Given this list of marker genes H2BC26, MTA1, PCK1, ARID1B, MBD3L2, TCF19, CREBBP, SF3B1, CHD8, CDK2AP1, SNRPB2, SUMO1, SMARCD3, BCL11B, NS, BCL7C, H2BC4, H4C1 (H4 clustered histone 1), H2AB1, RTF1, MBD3L1, IKZF3, SF3B4, NFE2L2, EP300 (E1A binding protein p300), CDK2AP2, BICRA, H2BC15, SNRPD2, SMARCA2, DPF2, H2BC14, SKIC8, CTCF, H2AC20, H2BC13, H2AC18, DPF3, PHF10, SS18, H2BC12, SS18L1, HDAC1, BICRAL, ADNP, PBRM1, NQO1, PAF1, ACTL6B, CTNNB1, CHERP, CDC73, SUPT16H, DDX46, ADNP2, SF3A3, NP, U2SURP, SF3B3, MBD3, TCF12, ACTL6A, RBBP4, PA, ARID2, PUF60, TCF4, CBX1, H2AC6, HDAC2, IKZF1, PHF5A, PB2, MTA3, NR2F2, CHD4, H2BC17, H2BC12L, H3-3A, H2AJ, PWWP2B, CTR9, ZNF687, SNRPG, CBX3, GATAD2B, H2AC14, NR2C2, SSRP1 (structure specific recognition protein 1), SF3B2, PHF6, H2BC1, DHX15, FAM124B, CHD1, H2AC4 (H2A clustered histone 4), CHD3, ARID1A, DPF1, H2AC7, ZMYND8, SMARCD2, H3C15, ZNF827, H2BC9, CHD7, FBP1 (NCBI Gene Id 2203), SNRPD3, MYOD1, GATAD2A, SMARCE1, SMARCA4, H2BC21, CHD5, BRD9, BCL7A, SF3A2, NKD2, SF3B5, IKZF2, H2BC11, MYOG, LEO1, CHD6, ACTB, TCF3, H2AZ2, ZNF532, SNRPE, SNRPF, CHD2, SF3A1, ZNF592, SNRPA1, SNRPD1, MAFK, H3C1, AXIN2, UBE2I, SNRPB, SMARCD1, BCL11A, CHD9, SMARCC1, G6PC1, H2BC5, MTA2, PWWP2A, RBBP7, RBM17, BCL7B (NCBI Gene Id 9275), SNRPN, H2AX, DDX42, DKK2, SMARCB1, IGF2, MBD2, WDR5, PB1, SMARCC2, BRD7, SF3B6, SMNDC1, H2BC3, here is a description of the gene set: part of: Chromatin organization studied in species Homo sapiens ATP-dependent chromatin remodelers use the energy from ATP hydrolysis to organize or rearrange nucleosomes by altering histone-DNA contacts. There are four main classes of mammalian ATP-dependent chromatin remodellers: SWI/SNF (for switch/sucrose non-fermenting, initially characterized in S. cerevisiae); ISWI (imitation switch), chromodomain helicase DNA-binding (CHD) and INO80 (inositol requiring mutant 80). Each of these complexes is characterized by a SWI2/SNF2-family ATPase domain that contributes the catalytic function and translocates the DNA along the histone core of the nucleosome. The remainder of the 1 - 1.5MDa complexes are made up of accessory proteins that modulate ATPase activity and contribute to target recognition and specificity by interacting with nucleosomes and histone tails.<br>Human SWI/SNF ATPases bind acetylated nucleosomes through the bromodomains of their two alternative catalytic subunits, SMARCA2 (also known as BRM) or SMARCA4 (BRG1). Histone and DNA contacts are also mediated by other protein components of the SWI/SNF complex. SWI/SNF chromatin remodellers are generally involved in gene activation or repression and provide access to chromatin by repositioning or ejecting nucleosomes.<br>Human CHD family ATPases contain one of nine catalytic CHD protein paralogs. DNA-binding is mediated by contacts between methylated histones and the chromodomain of CHD1-9, as well as through other protein constituents of the ATPase complex. CHD family ATPases are involved in diverse chromatin remodelling activities, including nucleosome assembly and spacing, access to regulatory elements and changes to histone composition.<br>Human ISWI family ATPases contain one of two potential catalytic subunits, SMARCA5 (also known as SNF2H) or SMARCA1 (SNF2L), that interact with unmodified histone tails through their SANT domains. ISWI complexes are generally involved in nucleosome maturation and regulation of spacing and assembly, often resulting in repressive gene states, but some are also involved in transcriptional activation.<br>Human INO80 family ATPases contain one of three catalytic subunits, INO80, SRCAP or EP400. INO80 complexes generally contribute more to histone exchange than to nucleosome spacing, assembly or access. Reactome Pathway: ATP-dependent chromatin remodelers